The following is a description of a gene set: Mouse Gene Set: GOBP_CD8_POSITIVE_ALPHA_BETA_T_CELL_PROLIFERATION The expansion of a CD8-positive, alpha-beta T cell population by cell division. species: Mus musculus, and this is the list of marker genes: Cd244a, Xcl1, Mapk8ip1, Lilrb4a, Sh3rf1, Irf1, Vsir, H2-T23, Slc4a2, Ptpn22